The following is a description of a gene set: Human Gene Set: REACTOME_NF_KB_ACTIVATION_THROUGH_FADD_RIP_1_PATHWAY_MEDIATED_BY_CASPASE_8_AND_10 studied in species Homo sapiens NF-kB activation through FADD/RIP-1 pathway mediated by caspase-8 and -10, and this is the list of marker genes: IKBKG, TRIM4, FADD, RNF135, IKBKB, MAVS, RIPK1, CASP8, TRIM25, CASP10, IFIH1 (interferon induced with helicase C domain 1), RIGI, CHUK